The following is a description of a gene set: Genes containing one or more binding sites for (ZNF488) in their promoter regions (TSS -1000,+100 bp) as identified by GTRD version 20.06 ChIP-seq harmonization. studied in species Homo sapiens Human Gene Set: ZNF488_TARGET_GENES from publication Yevshin I, Sharipov R, Kolmykov S, Kondrakhin Y, Kolpakov F (PMID 30445619), and this is the list of marker genes: LAMP1, LINC01780, HSD11B1-AS1, TSC22D4, CDC42EP4, LINC00933, PAXBP1, PRDM6, MIR615, RFTN1, SLC15A1 (NCBI Gene Id 6564), ALKBH3-AS1, ENSG00000224865 (novel transcript), ZNF674, GBA1, TNK2-AS1, EPCIP-AS1, LINC02794, CASC3, PRDM6-AS1, LINC00431, CCT6B, KIAA0319, HOXB3, RNU6-1039P, CCBE1, HOXA9, BRWD1, ALDH1A2 (NCBI Gene Id 8854), STAT6, ATXN7L1, INSM1, ELFN1-AS1, G0S2, MTFR2P2, UBE2Q2P1, FCHSD2, ZNF674-AS1, NEUROG3, NEUROG2, TSHZ2, LINC02609, KRT13 (keratin 13), ZNF217